The following is a description of a gene set: Human Gene Set: GOBP_COMMITMENT_OF_NEURONAL_CELL_TO_SPECIFIC_NEURON_TYPE_IN_FOREBRAIN species: Homo sapiens The commitment of neuronal precursor cells to become specialized types of neurons in the forebrain., and this is the list of marker genes: ASCL1, BCL11B (NCBI Gene Id 64919), TBR1, FEZF2, GATA2, PAX6